The following is a description of a gene set: Human Gene Set: YAGI_AML_WITH_T_9_11_TRANSLOCATION Most patients with acute myeloid leukemia (AML) enter complete remission (CR) after treatment with chemotherapy, but a large number of them experience relapse with resistant disease. To identify genes that are associated with their prognoses, we analyzed gene expression in 54 pediatric patients with AML using an oligonucleotide microarray that contained 12 566 probe sets. A supervised approach using the Student t test selected a prognostic set of genes, some of which are associated with the regulation of cell cycle and apoptosis. Most of these genes had not previously been reported to be associated with prognosis and were not correlated with morphologically classified French-American-British (FAB) subtypes or with karyotypes. These results indicate the existence of prognosis-associated genes that are independent of cell lineage and cytogenetic abnormalities, and they can provide therapeutic direction for individual risk-adapted therapy for pediatric AML patients. Genes specifically expressed in samples from patients with pediatric acute myeloid leukemia (AML) bearing t(9;11) translocation. from publication Yagi T, Morimoto A, Eguchi M, Hibi S, Sako M, Ishii E, Mizutani S, Imashuku S, Ohki M, Ichikawa H (PMID 12738660) studied in species Homo sapiens, and this is the list of marker genes: ACTR2, EVI5, ADCY9, PHYH, FEZ1, MYO6, SLC27A3, MRPL33, ATXN1, PENK, RHOA, RPN2, CKM, IDH3A, NDUFS6, IFI35 (interferon induced protein 35), H4C9, CCN4, RAD17, IRX5, BMI1, MUSK, TNPO1, FCN3, LGALS4, ZFR, CCL23, ERAP1, RUVBL1, JMJD1C, FZD2, AK2, SERTAD2, RYR1, LUM, MR1, KCTD7, TRIM44, ZEB2, MX2, CEMIP, CLASP2, BLCAP, GFRA1, IFNA2, ATXN10, GAPDHS, RFPL3S, VAMP8 (vesicle associated membrane protein 8), SMG1P5, MEF2C, ZFX, SMC1A, PBX3, CLASP1, SGCG, MOAP1, IMPG1, TRA2A, SLC25A36, APOC2, RUFY3, ZBTB11, TREX2, OFD1, GLA, NTRK3, OAS1 (NCBI Gene Id 4938), NARS1, FRMPD1, RBBP6, AKAP8, SNRNP200, MEIS1, DACH1, SF1, CHRNA7, DSTN, ZBTB25 (NCBI Gene Id 7597), F2 (NCBI Gene Id 14061, coagulation factor II), MSLN, PPP1R2, TGM5, KIAA0408, SATB1, MTERF4, TSC22D2, DDX39A, GRK3, FLNB, EFNB2, PDCD1, JTB, HSF2, CHUK (NCBI Gene Id 1147, component of inhibitor of nuclear factor kappa B kinase complex), RANBP6, ADAM23, LDLRAD4, FCGR1A (Fc gamma receptor Ia), PHKA2, CYLD, PLCG2, ITGA7, SRPK2, CNOT8, SRRT, ELP4, NDUFS3, FLT1, MGMT, IRAG2, TBCC, ABAT, ELF2, PALLD, WARS1, TWF1, PHIP, POP5, SOCS2, ITPA, IFI44L, BABAM2, DNAJC7, QPRT, CYP2E1, SCRIB, TOP2B, MDM4, ATP6V0B, PIGH